The following is a description of a gene set: Hematopoietic stem cell differentiation studied in species Homo sapiens Human Gene Set: WP_HEMATOPOIETIC_STEM_CELL_DIFFERENTIATION, and this is the list of marker genes: MIR15A, CBFA2T3, TRAF3IP3, FOS, GYPA, GATA2, MIR16-1, IKZF1, TRIM29, LEF1, IRF5, CSF1, ITGA2B, MXI1, IL1A, MUC1, TNXB, SPI1, CXCR4, KITLG, CSF2, GATA1, MIR128-1, FLI1, ITGB3, RIOK3, IL5, THRB, HES6, VAV1, NOTCH1, PIM1, GP9, MIR130A, NCKAP1L, IL3, MIR150, RUNX1, TPO, NFATC2, CIITA (NCBI Gene Id 4261), CD34, IL6, KLF1, MIR223, FOSB, LYL1, MIR181A1 (NCBI Gene Id 406995), KCNH2, MIR3074, ACVR1B, LMO2, ZNF835, RHOH, SEC14L2, HMGN5, EPO, STAT5A, IL1B, MIR221, CSF3, NFE2, MYB